The following is a description of a gene set: Colpocephaly Human Gene Set: HP_COLPOCEPHALY Colpocephaly is an anatomic finding in the brain manifested by occipital horns that are disproportionately enlarged in comparison with other parts of the lateral ventricles. studied in species Homo sapiens, and this is the list of marker genes: DHCR7, HNRNPH1, KDM1A, SEC31A, DNM1, FRA10AC1, NDE1, STAG2, PEX10, KIAA0586, KAT6B, NADK2, NDUFB11, NRCAM, NCAPG2 (non-SMC condensin II complex subunit G2), COX7B, RNU4-2, ZNF148, MPDZ, RNU4ATAC, ERMARD, ZNF462, FANCI, ANKRD11, CSPP1, ARSI, SRPK3, TUBA8, PPP1R12A (NCBI Gene Id 4659), ESAM, KIF26A, ACBD6, HCCS, DHX37, PEX2, PLXNA1